The following is a description of a gene set: electronically inferred by orthology from the curated human pathway Reactome Pathway: Transcription-Coupled Nucleotide Excision Repair (TC-NER) This event has been computationally inferred from an event that has been demonstrated in another species.<p>The inference is based on the homology mapping from PANTHER. Briefly, reactions for which all involved PhysicalEntities (in input, output and catalyst) have a mapped orthologue/paralogue (for complexes at least 75% of components must have a mapping) are inferred to the other species. studied in species Mus musculus part of: Nucleotide Excision Repair, and this is the list of marker genes: Uvssa, Gtf2h4, Ddb1, Tcea1, Rps27a (NCBI Gene Id 78294), Cul4b, Ubb, Ercc1, Cops6, Cul4a, Polr2b, Xab2 (NCBI Gene Id 67439), Polk, Ercc3, Pold4, Lig1 (ligase I, DNA, ATP-dependent), Pole2, Polr2f, Xpa, Xrcc1, Ercc6, Rfc1, Prpf19, Ercc2, Pcna, Rpa1, Pold2, Polr2i, Polr2a, Ccnh, Polr2k, Zfp830, Ercc4, Polr2l, Polr2c, Pole, Polr2e, Pold1, Gtf2h2, Rfc3